The following is a description of a gene set: Human Gene Set: GOBP_POSITIVE_REGULATION_OF_HAIR_FOLLICLE_MATURATION species: Homo sapiens Any process that activates or increases the frequency, rate or extent of hair follicle maturation., and this is the list of marker genes: MSX2 (NCBI Gene Id 8053), WNT5A, WNT10B, TGFB2, GAL